Given this list of marker genes SLC7A1, SLC38A9, SLC7A2, SLC25A29 (solute carrier family 25 member 29), SLC25A15, SLC25A2, SLC7A3, SLC66A1, SLC22A2, SLC7A7, SLC38A4, SLC7A6, SLC47A1, here is a description of the gene set: Enables the transfer of L-arginine from one side of a membrane to the other. Human Gene Set: GOMF_L_ARGININE_TRANSMEMBRANE_TRANSPORTER_ACTIVITY species: Homo sapiens